Given this list of marker genes NRN1, WNT5A, SNX18, ATP1B1, NET1, ZCCHC24, AKAP9, CTSF, ENDOD1, PERP, H4C1 (NCBI Gene Id 8359), TPR, RGS5, PFN1, HSD17B11, IGF2R, PC, FAT4, RCOR3, HMGA2, MAP1B, CUL5 (NCBI Gene Id 8065), NPR3, IGF2, COL2A1, NFIA, TUBB2B, MAP3K2, SPTBN1, FGFR2 (NCBI Gene Id 2263), GRPR, PARM1, PTK7, PPP1R3C, RGS17, TPM1, CREBBP, COL3A1, THOC2, ST3GAL5, SELENBP1, ANGPT4, TNPO2, MPPED2, DDX6, ARGLU1, PAX1, ATXN2, GOLGA4, CENPE, ANKRD11, SRPK2, MARF1, AGO2, HNRNPL, CDO1, MEG8, RICTOR, MALAT1, TINAGL1, CAP1, CHODL (chondrolectin), CPD, CD14, FOXA1, SNCG (synuclein gamma), SNAPC3, GPC6, RESF1, CADM4, COX6B2, CDKN1C, CLCA3P, ATRX, CYP39A1, LOXL2, SESN3, GPC3, RGS4, INO80D, CACNA1H, PLEKHG1, SLC27A3, IFI44, PEG3, PCSK5, SEMA3B, SOX2, MYH11, TSPAN5, ATP9A (ATPase phospholipid transporting 9A (putative)), CAMK2D, RC3H2, NNAT, SLC12A2, NFIB, RBFOX2, CBL, KDM5A, RORA, DPYSL4, PIK3R1, GNB1, TMTC4 (transmembrane O-mannosyltransferase targeting cadherins 4), SLC14A1, MSI2, MYBL1 (MYB proto-oncogene like 1), LUZP1, PTH1R, here is a description of the gene set: Transforming growth factor beta (TGF-beta) and platelet-derived growth factor A (PDGFAlpha) play a central role in tissue morphogenesis and repair, but their interplay remain poorly understood. The nuclear factor I C (NFI-C) transcription factor has been implicated in TGF-beta signaling, extracellular matrix deposition, and skin appendage pathologies, but a potential role in skin morphogenesis or healing had not been assessed. To evaluate this possibility, we performed a global gene expression analysis in NFI-C(-/-) and wild-type embryonic primary murine fibroblasts. This indicated that NFI-C acts mostly to repress gene expression in response to TGF-beta1. Misregulated genes were prominently overrepresented by regulators of connective tissue inflammation and repair. In vivo skin healing revealed a faster inflammatory stage and wound closure in NFI-C(-/-) mice. Expression of PDGFA and PDGF-receptor alpha were increased in wounds of NFI-C(-/-) mice, explaining the early recruitment of macrophages and fibroblasts. Differentiation of fibroblasts to contractile myofibroblasts was also elevated, providing a rationale for faster wound closure. Taken together with the role of TGF-beta in myofibroblast differentiation, our results imply a central role of NFI-C in the interplay of the two signaling pathways and in regulation of the progression of tissue regeneration. from publication Plasari G, Calabrese A, Dusserre Y, Gronostajski RM, McNair A, Michalik L, Mermod N (PMID 19752192) studied in species Mus musculus Human Gene Set: PLASARI_TGFB1_SIGNALING_VIA_NFIC_1HR_DN Genes down-regulated after 1 h of TGFB1 stimulation in MEF cells (embryonic fibroblast) with NFIC knockout vs wild type MEFs.